The following is a description of a gene set: studied in species Homo sapiens Human Gene Set: chr18q22, and this is the list of marker genes: LINC01912, TIMM21, LINC01538, HMSD, RNA5SP460, DSEL-AS1, LARP7P3, ENSG00000287646, TSHZ1, SERPINB8, GTSCR1, HNRNPA1P11 (heterogeneous nuclear ribonucleoprotein A1 pseudogene 11), DSEL, LINC01541, LINC01924, MIR548AV, ENSG00000286800, ZNF407-AS1, RN7SL795P, ENSG00000265484, LINC02582, LINC01899 (long intergenic non-protein coding RNA 1899), SOCS6, PRPF19P1, RPL12P39, CDH7, ENSG00000263594, RPS2P6, LINC01910, FBXO15, DOK6, ENSG00000303945, MTL3P, LIVAR, ENSG00000293054, LINC00305, CNDP2, RN7SL551P, PTGR3, FAM32DP, MIR5011, NETO1, ZNF407, LINC01903, ENSG00000287314, CCDC102B, CYB5A, CDH19, RPL31P9, LINC02864, SDHCP1, TMX3, RN7SL401P, RNU6-39P, AKR1B10P2, CD226, C18orf63, NETO1-DT, LINC01909, SERPINB10 (NCBI Gene Id 5273), LINC01916, RTTN, LINC01922, RNU6-1037P, CNDP1, DIPK1C, ENSG00000287693, CBLN2, FAUP1